Given this list of marker genes XRN1, TRIR, EXOSC6, EXOSC5, DDX49, EXOSC7, DIS3, SLFN12, DIS3L, EXOSC8, EXOSC9, PELO, EXOSC4, SLFN13, SLFN14, DEDD2, ERN2, here is a description of the gene set: The chemical reactions and pathways resulting in the breakdown of rRNA, ribosomal RNA, a structural constituent of ribosomes. Human Gene Set: GOBP_RRNA_CATABOLIC_PROCESS studied in species Homo sapiens